Given this list of marker genes Myh9 (myosin, heavy polypeptide 9, non-muscle), Ska1, Ska3, Mos, Spire1, Fmn2, Ska2, Spire2, here is a description of the gene set: studied in species Mus musculus The cell cycle process in which the directed movement of the meiotic spindle to a specific location in the cell occurs. Mouse Gene Set: GOBP_ESTABLISHMENT_OF_MEIOTIC_SPINDLE_LOCALIZATION